Given this list of marker genes Slc22a1, Tomt (transmembrane O-methyltransferase), Slc6a3, Slc22a2, Aldh2, here is a description of the gene set: electronically inferred by orthology from the curated human pathway Reactome Pathway: Neurotransmitter clearance studied in species Mus musculus This event has been computationally inferred from an event that has been demonstrated in another species.<p>The inference is based on the homology mapping from PANTHER. Briefly, reactions for which all involved PhysicalEntities (in input, output and catalyst) have a mapped orthologue/paralogue (for complexes at least 75% of components must have a mapping) are inferred to the other species. part of: Transmission across Chemical Synapses